The following is a description of a gene set: Human Gene Set: GOBP_MITOCHONDRIAL_GENE_EXPRESSION studied in species Homo sapiens The process in which a mitochondrial gene's sequence is converted into a mature gene product or products (proteins or RNA). This includes the production of an RNA transcript as well as any processing to produce a mature RNA product or an mRNA or circRNA (for protein-coding genes) and the translation of that mRNA or circRNA into protein. Protein maturation is included when required to form an active form of a product from an inactive precursor form., and this is the list of marker genes: EARS2, MTERF1, MRPL36, AARS2, MRPS22, MRPL33, MRPS9, MRPS18C, MRPL58, MRPL17, LRPPRC, TFB2M, PTCD1, MRPL12, MRPL4, MTO1, RARS2, MRPS15, MRPL15 (mitochondrial ribosomal protein L15), MTG2, METTL8, KANSL3, MRPL24, SLC25A33, MRPS21, SHMT2, MRPL9, KAT8, MTERF4, TRMT5, OXA1L, FOXO3, MRPL14, GATC, MRPL40, MTIF3, MRPS6, YARS2, MIURF, MRPL23, MRPL20, PNPT1, MRPS10, MRPL11, FASTK, MRPL51, GTPBP3 (GTP binding protein 3, mitochondrial), MRPS34, MTRES1, MRPL53, MTERF2, MRPL37, AURKAIP1, IARS2, MRPL46, MRPS35, MRPL47, TRUB2, NSUN3, GARS1, WARS2, MRPL42, MRPL52, MRPS18A, MRPL54, COA3, QRSL1, MRPL43, MRPL18, TUFM, TRMT10C, DARS2, MRPL3, TWNK, TSFM, MRPS30, ALKBH1, LARS2, MTPAP, TBRG4, MRPL50, MRPS27, MRPS5, FASTKD1, HARS1, MRPL48, TEFM, TFAM, TARS2, MTIF2, MRPL16, RPUSD4, C1QBP, THAP11, MRPL19, DDX3X, METTL4 (methyltransferase 4, N6-adenosine), GFM2, KANSL1, CHCHD10, MRPL22, ELAC2, MRPL30, MRPS33, MRPS12, MPV17L2, PTCD3, TACO1, RCC1L, TFB1M, ANGEL2, GADD45GIP1 (GADD45G interacting protein 1), MRPS7, MTG1, MRPS11, MRPS2, MRPL55, POLRMT, GATB, UQCC2, MRPL27, PUS1, MALSU1, PRORP (protein only RNase P catalytic subunit), MRPL39, MRPL28, MRPS28, RPUSD3, MRPL21, MRPS25, MRPL49, DAP3, NGRN, MRPS16, PRKAA1, MRPS17 (NCBI Gene Id 64958), TRMT61B, CDK5RAP1, MRPS24, SUPV3L1, MRPL32, MRPL38, MRPL44, MRPL41, MRPL13, MRPS23, MTERF3, FASTKD2, CHCHD1, MTRF1L (NCBI Gene Id 54516), MRPS14, FASTKD3, GFM1 (G elongation factor mitochondrial 1), SARS2, MTRF1, MRPL35, MRPS26, MRPL2, FASTKD5 (FAST kinase domains 5), MRPL10, MRPL45, MRPL57, MRPL1, RMND1, MRPL34, MRPS31, MRPS18B, TRNT1, TRIT1, HSD17B10